The following is a description of a gene set: Any process that results in a change in state or activity of a cell (in terms of movement, secretion, enzyme production, gene expression, etc.) as a result of a L-glutamate(1-) stimulus. Human Gene Set: GOBP_CELLULAR_RESPONSE_TO_L_GLUTAMATE studied in species Homo sapiens, and this is the list of marker genes: GRIA1, FYN, BCL11A, BAIAP2, GRIN2D, HPCA, AMIGO1, PRKN, ABCB1